Given this list of marker genes TMEM94, TEAD1, H1-4, PITX1, AKR7A2 (aldo-keto reductase family 7 member A2), RSF1, MTMR11 (myotubularin related protein 11), FSD1L, FOXP2, AK9, SYT16, ORC4, SIX1, SP1, IRX4, BARHL1, LRR1, PDE1A, CBFA2T2, PTCHD4, CD55, OIP5, LDB2, CYP2E1, FKRP, NFYC, NEK10, H3-4, RAG1, HIGD1A, NUSAP1, GSG1, KCNQ1DN, SLC1A7, FAM53C, DCN, SPTB, NAP1L5, PGM1, PANX3, SLC66A1, RHOQ, NSD1, CLRN1 (NCBI Gene Id 7401), AGAP3, AARS2, H2BC5, HOXA2, CALD1, TRERF1 (NCBI Gene Id 9565), GNAS, STRN4, CLDN16, KRT32, L3MBTL2, SYNPR, FAM107B, STAG2, GSE1, TMOD3, OPCML, RFX5, HOXD12, AAMDC, CADM1, MARK3, IRAK1, FGFR2, DSG1, GPR65, here is a description of the gene set: studied in species Homo sapiens Comprehensive identification of all functional elements encoded in the human genome is a fundamental need in biomedical research. Here, we present a comparative analysis of the human, mouse, rat and dog genomes to create a systematic catalogue of common regulatory motifs in promoters and 3' untranslated regions (3' UTRs). The promoter analysis yields 174 candidate motifs, including most previously known transcription-factor binding sites and 105 new motifs. The 3'-UTR analysis yields 106 motifs likely to be involved in post-transcriptional regulation. Nearly one-half are associated with microRNAs (miRNAs), leading to the discovery of many new miRNA genes and their likely target genes. Our results suggest that previous estimates of the number of human miRNA genes were low, and that miRNAs regulate at least 20% of human genes. The overall results provide a systematic view of gene regulation in the human, which will be refined as additional mammalian genomes become available. Genes having at least one occurrence of the highly conserved motif M147 YAATNANRNNNCAG in the regions spanning 4 kb centered on their transcription starting sites. The motif does not match any known transcription factor binding site. Human Gene Set: YAATNANRNNNCAG_UNKNOWN from publication Xie X, Lu J, Kulbokas EJ, Golub TR, Mootha V, Lindblad-Toh K, Lander ES, Kellis M (PMID 15735639)